Given this list of marker genes LCK, PRKCD, ALCAM, CSRP1, HOXB7, BDH1, SPIB, TES, GPM6A, ARL4A, MS4A1, IL4R, IFNGR2, LYN, CSPG5, STS, GPR65, ADAM28, ITGB2, EMP3, RGS4, CDC25B, PIP5K1B, NDUFS5, ST8SIA1, SWAP70, HCK, SIK1 (salt inducible kinase 1), AHCY, PEG10, AQP7, IRF4, ASMT, PWP2, KIF21B, PCDH9, INSL4, RIPOR2, ENDOD1, SPAG1 (sperm associated antigen 1), CD1C, AZGP1, EXOC3, NRGN, UVRAG, STK17B, MTSS1, CD1D, ADAM19, SAMHD1, SELENOW, FBXW4P1, GARRE1, LAMA5, GGA2, NADK, PALS2, SPP1, AHNAK, SLC27A2, CD48, CSTF2, WAPL, SYNJ2, CCR6, KLF9, UGT8, IRAG2, BCL7A, RHOBTB1, SYNE1, GLDC, TTN, SUSD6, CCNE1, BIRC3, TNFRSF17, PKIA, TSR1, ENTPD1, MTHFD1, CRYM, DTX4, DHCR24, ABR, IL7R, NT5E, CD180, CXCL11, MTX2, CMA1, EIF4A3, S1PR1, HDAC9, SORD, IRS1, NUP210, RGS10, MAST3, JAG1, CD52, IRF5, ROR1, IGHD, TTF2, ADARB1, IFI30, NFIL3, UGT2B15, ASNS, GCNT1, PDGFRA (NCBI Gene Id 5156), CR2, GNAZ, SIT1, LIG1, RRN3P1, ICAM3, SETBP1, TRIB2, RASGRP1, GPT, TFDP2, TNFAIP8, CD83, SLA, CBX1, SLC17A4, ADAM8, GM2A, DAAM1, GALE, FST, TACC1, SNX29P2, CEMIP, TJP1, IL27RA, TMT1A, RS1, ACY1, VNN2, LY86 (lymphocyte antigen 86), TCL1A, RNASE6, PPP1R16B, TBC1D9, CXCL1, RHOH, COCH, SP140, SLC7A7, KMO, IZUMO4, AEBP1, PLCH2, PTPN21, TGFBR2, PTPRM, MICAL3, APBB2, CRIP1, SIGLEC6, RAB29, SH3BP5, DPH2, NDUFS7, RFC5, CD19, EPHA4, ABCB4, FCHSD2, MMP17, NUP160, HEXA, APOBEC3B, ATP2B1, GLS2, PTPN18, AOX1, HLA-DOB, MTMR1, CCDC69, CD72, RNGTT, PTPN22, INPP4A, PTPN6, PDLIM1, PTPRK, DAZL, SIPA1L1, GPR18, TRAT1, TEAD4, SNAPC2, FER, ST6GAL1, AGL, here is a description of the gene set: Human Gene Set: GSE39556_UNTREATED_VS_3H_POLYIC_INJ_MOUSE_CD8A_DC_UP species: Homo sapiens The injection of the pathogen-associated molecular pattern Polyinosinic-polycytidylic acid (poly(I:C)) leads to the activation of various immune cells, including dendritic cells (DCs) and Natural Killer (NK) cells. This activation is due to different innate cytokines produced early after injection, in particular IFN-I. The objective of the study was to compare the pattern of expression of IFN-I stimulated genes between DC and NK cells. The project focused on a specific subset of conventional DC, CD8a DC, which responsiveness to IFN-I determines the capacity to activate CD8 T cells by cross-presentation of exogenous antigens. To identify the responses to IFN-I selectively induced in CD8a+ DC, we compared their gene expression profile to that of NK cells, using gene chips, before and after poly(I:C) stimulation. from publication Baranek T, Manh TP, Alexandre Y, Maqbool MA, Cabeza JZ, Tomasello E, Crozat K, Bessou G, Zucchini N, Robbins SH, Vivier E, Kalinke U, Ferrier P, Dalod M (PMID 23084923) Genes up-regulated in CD8A dendritic cells: untreated versus poly(IC).